Given this list of marker genes ATP6AP2, SOX17, KDM2B, FGF8, SSBP3, EN1, HES1, BMI1, PAX6, WNT1, GBX2, here is a description of the gene set: The process in which the neural tube is divided into specific regions along the rostrocaudal axis. Human Gene Set: GOBP_ROSTROCAUDAL_NEURAL_TUBE_PATTERNING species: Homo sapiens